The following is a description of a gene set: species: Homo sapiens Neighborhood of MCM5 MCM5 minichromosome maintenance deficient 5, cell division cycle 46 (S. cerevisiae) in the GNF2 expression compendium Human Gene Set: GNF2_MCM5 Neighborhood of MCM5, and this is the list of marker genes: SERBP1, MCM7, MCM4, PCNA, SMC1A, CPSF6, HMGB2, SFPQ, SNRPG, SMC4, HNRNPU, NOP56, HNRNPA3P1, DEK, ZWINT, VRK1, FEN1, SF3B3 (NCBI Gene Id 9661), SLBP, U2SURP (U2 snRNP associated SURP domain containing), NUP62, NUP153, LMNB1, PA2G4, MCM3, CENPM, SKIC8, SRSF1, MCM5, ANP32B, TOPBP1, GINS1, DUT, HAT1, MCUR1, RBMX, SSRP1, IFT25, TOP2A, LAS1L, CDCA8, NASP, EXOSC8, SUZ12, PTBP1, APEX1, RRM1, GINS2, MCM2, POLA2, DKC1, TRA2B, EED, TYMS, DHX15, NOP14 (NOP14 nucleolar protein), NDC80, HNRNPAB, SRI, DTL, USP1